The following is a description of a gene set: Mouse Gene Set: GOBP_REGULATION_OF_TYPE_I_INTERFERON_MEDIATED_SIGNALING_PATHWAY studied in species Mus musculus Any process that modulates the rate, frequency or extent of a type I interferon-mediated signaling pathway., and this is the list of marker genes: Cactin, Mul1, Rbm47, Wnt5a, Oas1f, Dcst1, Fadd, Ptpn2, Oas1d, Usp29, Rnf185, Trim56, Smim30, Sting1, Oas1b, Ikbke, Irf3, Trim41, Isg15, Nlrc5, Irf7, Lsm14a, Trex1, Trim6 (NCBI Gene Id 94088), Usp27x, Usp18, Stat2, Oas3, Cdc37, Ube2k, Ythdf3, Mettl3, Zbp1, Gigyf2, Oas1c, Cnot7, Mavs, Eif4e2, Ythdf2, Oas1e, Oas1g, Oas1a (2'-5' oligoadenylate synthetase 1A), Oas1h, Adar, Ttll12, Samhd1, Tbk1, Mmp12